Given this list of marker genes Slc2a13, Slc5a3, here is a description of the gene set: part of: SLC-mediated transmembrane transport This event has been computationally inferred from an event that has been demonstrated in another species.<p>The inference is based on the homology mapping from PANTHER. Briefly, reactions for which all involved PhysicalEntities (in input, output and catalyst) have a mapped orthologue/paralogue (for complexes at least 75% of components must have a mapping) are inferred to the other species. studied in species Mus musculus electronically inferred by orthology from the curated human pathway Reactome Pathway: Inositol transporters